Given this list of marker genes SLC2A5, ADAM10, CD177, DNAJC5, RAP2B, TMEM63A, LAMTOR1, ATP6V1D, STK10, FCAR, CD33, SLC15A4, CEACAM1, MS4A3, CD47, PLAUR, KCNAB2, UBR4, ITGAV, CLEC12A, BST1, CD59, CHRNB4, PGRMC1 (NCBI Gene Id 10857), STOM, GPR84, ITGB2, ATP8A1, SNAP25, LAIR1, CD36, MLEC, ORMDL3, VAMP1 (NCBI Gene Id 6843), CEACAM3, ANO6, MOSPD2, MCEMP1, SLCO4C1, RAP1A, TNFRSF1B, TSPAN14, LAMTOR2, LILRA3, RAB44, ALDH3B1, CEACAM8, PTPRB, SLC44A2, CMTM6, ATP11A, CLEC5A, HVCN1, PTPRJ, TOM1, CD93, ITGAM, TRPM2, RAB37, TMBIM1, TARM1, TMEM30A, SNAP23, PLD1, AP1M1, HGSNAT, MMP25, LAMTOR3, TMC6, ADAM8, FPR2, CD53, ADGRG3, ATP8B4, CLEC4D, ITGAL, AGPAT2, CKAP4, PLAU, SLC2A3, OLR1, DEGS1, SCAMP1, CYBA, SLC27A2, CYBB, P2RX1, HMOX2, VAMP8, C3AR1, DGAT1, here is a description of the gene set: The lipid bilayer surrounding a specific granule, a granule with a membranous, tubular internal structure, found primarily in mature neutrophil cells. Most are released into the extracellular fluid. Specific granules contain lactoferrin, lysozyme, vitamin B12 binding protein and elastase. Human Gene Set: GOCC_SPECIFIC_GRANULE_MEMBRANE species: Homo sapiens